The following is a description of a gene set: studied in species Mus musculus Mouse Gene Set: GOBP_NEGATIVE_REGULATION_OF_TYROSINE_PHOSPHORYLATION_OF_STAT_PROTEIN Any process that stops, prevents, or reduces the frequency, rate or extent of the introduction of a phosphate group to a tyrosine residue of a STAT (Signal Transducer and Activator of Transcription) protein., and this is the list of marker genes: Pibf1, Hnf4a, Inpp5f, Traf3ip1, Cav1 (NCBI Gene Id 12389), Irf1, Socs1, Ggnbp2, Suz12, Parp14, Socs3, Ptpn2, Nf2